The following is a description of a gene set: Human Gene Set: GOBP_REGULATION_OF_KERATINOCYTE_PROLIFERATION studied in species Homo sapiens Any process that modulates the rate, frequency or extent of keratinocyte proliferation. Keratinocyte proliferation is the multiplication or reproduction of keratinocytes, resulting in the expansion of a cell population., and this is the list of marker genes: OVOL1, STXBP4, CD109, REG3G, EPPK1, EXTL3, IFT57, MIR125B1, ZEB1, NOTCH2, CRNN, FGFR2, SRSF6, PRKD1, CDH3, FGF7, KDF1, MED1, CASK, ZFP36, IRF6, MIR21 (NCBI Gene Id 406991), MDK, HAS2, BCL11B, AREG, SFN, GPR15LG, KLF9, INTU, IFT172, LRG1, VDR, IFT80, ZFP36L1, REG3A, IFT52 (NCBI Gene Id 51098), EPB41L4B, TP63, TGM1, FGF10, PTPRK, IFT74, OVOL2, SLURP1, YAP1, SNAI2, EFNB2, PTCH1